The following is a description of a gene set: studied in species Mus musculus Mouse Organogenesis Cell Atlas (MOCA) DE_gene_main_cluster.csv, fold.change>=1.5, qval<0.05, pval<0.05 from publication Cao J, Spielmann M, Qiu X, Huang X, Ibrahim DM, Hill AJ, Zhang F, Mundlos S, Christiansen L, Steemers FJ, Trapnell C, Shendure J (PMID 30787437) Mouse Gene Set: DESCARTES_ORGANOGENESIS_CHOLINERGIC_NEURONS, and this is the list of marker genes: Prkn, Megf11, Vldlr, Kcnab1, Hecw2, Ret, Tnr, Ina (internexin neuronal intermediate filament protein, alpha), Slit3, Entrep2, Mnx1 (motor neuron and pancreas homeobox 1), Rimbp2, Crmp1, Tppp3, Cers6, Phox2b, Gm20319, Tspan17, Chat, Slc5a7, Scg2, Gm31592, Sema6d, Galnt14, Nptx2, Cdh12, Gm2990, Rbp1 (retinol binding protein 1, cellular), Tmem132d, Asap1, Crtac1, Gm16141, Kcnh8, Fry, Oacyl, Grip1, Slc18a3, Dlc1, Olfm2, Stk32a, Tspan5, Rasgef1c, Gng2, C1ql1, Rai2, Ngfr, Nyap2, Slc10a4, Ncam1, Lhx3, Sfmbt2, Sertm2, D930028M14Rik, Marchf11, Ecel1, Hoxc8, Gm10530, Gm14696, Adcy2, Mxra7, Crp, Clstn2, Uts2b, Tafa5, Mfap3l, St6galnac5 (ST6 (alpha-N-acetyl-neuraminyl-2,3-beta-galactosyl-1,3)-N-acetylgalactosaminide alpha-2,6-sialyltransferase 5), Pcdh7 (NCBI Gene Id 54216), Arhgap36, Marchf4, Phox2a (paired-like homeobox 2a), Enox2 (ecto-NOX disulfide-thiol exchanger 2), Nefl, G630064G18Rik, Snx18, Mcc, Rgs7, Lhx4, Gnat3, Nwd2, Elavl2, Nefm, Hspa12a, Grip1os2 (glutamate receptor interacting protein 1, opposite strand 2), Gpr149, Tanc2